Given this list of marker genes Notch1, Traf5, Srsf1, Il17ra, Traf2, Trim32, Il17a, Traf6, Traf3ip2, Il17f, Ikbke, Usp25, here is a description of the gene set: Mouse Gene Set: GOBP_INTERLEUKIN_17_MEDIATED_SIGNALING_PATHWAY species: Mus musculus The series of molecular signals initiated by interleukin-17 binding to its receptor on the surface of a target cell, and ending with the regulation of a downstream cellular process, e.g. transcription.